The following is a description of a gene set: Any process that regulates the concentration of calcium in the postsynaptic cytosol. studied in species Homo sapiens Human Gene Set: GOBP_REGULATION_OF_POSTSYNAPTIC_CYTOSOLIC_CALCIUM_ION_CONCENTRATION, and this is the list of marker genes: SLC8A2, CALB1, SLC8A3, ATP2B2, GRM1, WNT5A, GRID2IP, GRM5, ITPR1